Given this list of marker genes SDHB, NF1, SDHAF2, CCND1, KIF1B, VHL, MDH2, SDHA, SDHD, SDHC, DLST, PTEN, MAX, RET, BMPR1A, TMEM127, SLC25A11, FH, here is a description of the gene set: studied in species Homo sapiens A hemangioblastoma is a benign vascular neoplasm that arises almost exclusively in the central nervous system. Hemangioblastomas consist of a tightly packed cluster of small blood vessels forming a mass of up to 1 or 2 cm in diameter. Hemangioblastoma Human Gene Set: HP_HEMANGIOBLASTOMA